Given this list of marker genes ADCY6, PIK3CB, GJA1, PRKAR1A, P2RX7, NFKB1, IKBKG, HSPG2, CALM1, IKBKB, GNG11, GNGT1, PTPN1, RICTOR, GNG10, PRKAR2A, SPP1, TRPV4, PIEZO1 (NCBI Gene Id 9780), NLRP3, PPP2R1A, ADCY5, PRR5, GNB3, CDH5, CACNB2, ADM, ANXA2, ITGB3, CAPN2, PKN2, TLN1, GNG5, PIK3CA, PRKAR2B, ABL1, FN1, GNG4, PANX1, GNB5, CACNA2D1, CALCRL, PRKACB, GNGT2, ITGB1, CACNB3, PRKACG, CTNNB1, ADCY9, ADCY3, IKBKE, CACNB1, FLT4, CACNG7, ADCY8, PTK2, GNG13, GNG7, GNG2, GNB2, CACNA1H, CHUK, CAPNS1, ADCY2, GNAS, GNA11, FYN, GNG8, RAMP2, ITGA5, PIK3R2, P2RY2, CAPNS2 (calpain small subunit 2), GNAQ, ITGAV, PPP2R1B, GNB4, AKT1, MLST8, NOS3, NFKBIA, MAPKAP1, ADCY7 (adenylate cyclase 7), PRKACA, PPP2R2A (protein phosphatase 2 regulatory subunit Balpha), PDPK1, PDE4D, PRKAR1B, GNB1, PIK3CD, ADCY1, YAP1 (Yes1 associated transcriptional regulator), KDR, GNG12, GNG3, STAT1, VCL, PECAM1, MTOR, RELA, MMP14, ADCY4, PPP2CA, here is a description of the gene set: Human Gene Set: REACTOME_CELLULAR_RESPONSES_TO_MECHANICAL_STIMULI studied in species Homo sapiens Cellular responses to mechanical stimuli